Given this list of marker genes GALNT3, MOSPD1, C2orf88, SIK2, ROBO2, ADIPOR2, RNF103, ZNF236, RUNX2, RAD51B, MTURN, PTPRA, OTUB2, HCFC1, ZNF333, GNG3, MDGA1, KCNK15, COL10A1, KLHL13, SERINC5, NCAN, TMEM132B, DCBLD2, BCL9, SLAIN1, GPR63 (NCBI Gene Id 81491), SMCHD1, PRMT3, RIMS1, MITF, SFRP2, FAM81A, NXT2, WDR48, KIRREL3, HS3ST2, CCDC6, PPP1CC, UGT8, TTC39C, PAG1, SCAF11, CNN1, KALRN (kalirin RhoGEF kinase), HIVEP1, SETBP1, CUL3, MIER3, ADO, RIMBP2, TMEM178A, PLPPR4, SHC4 (NCBI Gene Id 399694), SLC5A3, ZC4H2, MRPL19, CERT1, EXD2, SGPL1, PKP4, RRP1B, SDC2, TRIM71, TMX1, TEX56P, ZWILCH, LRRC19, GASK1B, SOCS3, NACC1, CNTNAP2, TAC1, KLF9, TANC2, SH3D19, ASIC1, SEMA6A, INSYN2A, DAAM1, RTN3 (reticulon 3), TBC1D8B, CCDC88A, RABEP1, SCAI, TRIM9, USP34, DDX6, H6PD, ZDHHC15, BCAT1, MSL2 (MSL complex subunit 2), ATL1, KLF8, NPY1R, TNC, HPGD, MINDY2, RHOQ, PCDH8, LRCH1, CSDE1, VOPP1, SERTAD2, RABGAP1L, INTS6, OBI1, PCLO, PHC3, RCBTB1, TYROBP, GALNT13, ZEB2, MBNL2, VAMP7, SHISA6, JMY, GAB2, SV2A, SEMA6B, KCTD16, ITM2C, RAB8B, VASH2, SHANK2, SLC6A17, SCN2B, HAPLN1, PNPLA8, APH1B, GPR161, SLC16A10, PPP2CB, CTNND2, MAGI2, MID2 (NCBI Gene Id 286440), ZNF705A, SPON1, PLA2R1, COPS3, GNAI3 (G protein subunit alpha i3), ZNF705EP, WDR47, ARF6, ABCG4, PUM2, PDE7A (NCBI Gene Id 5150), RGS20, BIRC5, TMEM151A, ADAMTS5, GSKIP, PCGF2, C3orf70, THOC2, ALAS2, TPBGL, ARB2A, MTMR1, L3MBTL3, TRPC3, C6orf62, EGLN3, RICTOR, CCNT1, ELFN2, NAA15, RCC1, PLD5, VSIG10, SH3KBP1, ADGRB3, MAP3K2, CA2, YEATS4, PLEKHF2, BMI1, GABRB3, SHTN1, ARK2C, SHOC2, PHAF1, GPR45, PLPP3, RNF139, TMEM25, ELOVL5, CTSO, WNT2B, CADM2, EDEM1, CDH8, ZNF471, GRIK2, ONECUT2, RET, POU2F1, ATOSA, KCND2, KLHL11, ACSL1, STXBP1, DPP6, SCRT1, ELMO1, UBQLN2, HP1BP3, JADE1 (NCBI Gene Id 79960), MDGA2, SREK1, FAM217B, PLXNC1, STAM2, GLUL, ADRB1, SORCS1, SH3RF1, FBXL2, LHFPL6, TMEM163, KRTAP5-5, THAP6 (NCBI Gene Id 152815), KCNQ3, SLAIN2, FLRT3, PPARGC1A, HOXD10, NAPEPLD, ANKRD44, ZFX, GPAM, PRKG1, ELOVL4, PKHD1, ANKRD27, INHBB, KCNQ5, DBN1, VPS13C, FCHO2, JADE2, UBE2H, EPHA5, BEND3, RELN, RHOBTB1, DNAL1, GOLGA7, HCN3, COMMD3-BMI1, ARL8B, SRPRB (NCBI Gene Id 58477), SLC1A2, DUSP5, RARA, GFPT1, SNTB2, KCNIP3, FBXO41, SLC16A7, DCUN1D4, PEX5L, TSPAN5, BBX, SEPHS1, LRIG1, VAT1, BZW2, OLIG2, EBF2, CHM, WDR44, C11orf87, HS3ST3B1, CCNI, NEXMIF, GUCY1A2, ROBO1, KCNK2, SLC17A6, CTTNBP2NL, UBR3, IKZF1, MTMR12, SHLD1, GLCE, TFAP2E (NCBI Gene Id 339488), SERPINI1, TRHDE, GRIA2, PIK3C2A, SPAG9, PBX2, CCER2, KDM3B, RNF114, NRXN1, IQCJ, GRAMD4, GADL1, PPP2R5A, ZNF831, SFMBT1, SHC3, TXLNG, SLC6A1, SNX18, MED17, EBF3, CACNB4, LRP1B, CDC42SE2, LASP1 (NCBI Gene Id 3927), RFX3, UBE3A, PI4K2A, GNAI2, CREB1, DCDC2, DPF3, MYT1L, RCOR1, TXNDC5, PRG4, CCDC50, SLCO5A1, SMPD3 (sphingomyelin phosphodiesterase 3), SERP1, GRIP1, EIF5A2, GRM1, NUP50, KLHL29 (NCBI Gene Id 80137), MAST4, GPR153, ABRAXAS2, FOXN3, USP32 (ubiquitin specific peptidase 32), RNF38, ZFYVE26 (NCBI Gene Id 338378), GNB1, SYT13, B3GAT1, NAV3, MYF5, SACS, MST1R, GPM6A, CLEC5A, HOOK1, MTMR6, EPHA7, LPCAT1, COPG2, RNF41, PPP2R2A, PLCL2, UBE2Q2, PHF24, RAPGEF4, GABRB2, NPAS2, REPS2 (NCBI Gene Id 9185), RIF1, KLF12, SNX4, MAFG, MYSM1, PIAS1, RIPOR2, ZMIZ1, RANBP10 (NCBI Gene Id 57610), MOCS2, SORBS1, TRPS1, PIEZO2, CPNE8, DCUN1D1, INSYN2B, UBE2D1, FUT9, KCNH1, TOX3, TMEM150C, GPR183, COMMD8, UEVLD, GNAS, MCF2 (NCBI Gene Id 4168), SGCZ, SOX11, FGF12, ZBTB34, KIF13A, EBF1 (NCBI Gene Id 1879), ERC2, NFATC3, DLG2, COQ7, KCNT1, HECTD2, CILK1, KIF21B, SHMT1, ZRANB1, TUB, IPO8, RASSF2, ARAP2, CYBRD1, SEC61A1, IKBKB, TRMT9B, NHSL3 (NCBI Gene Id 57648), DIRAS1, FAM3C, BRINP3, CACNA1I, EPHA8, GJA1, SLC45A3, THSD7A, ZBTB11, NMT2, CSMD3, KCNB1, LCORL, MYORG, MLLT3, SPECC1L, CALN1, CETN2, here is a description of the gene set: Genes predicted to be targets of miRBase v22 microRNA hsa-miR-218-5p in miRDB v6.0 with MirTarget v4 prediction scores > 80 (high confidence targets). Human Gene Set: MIR218_5P studied in species Homo sapiens from publication Chen Y, Wang X (PMID 31504780)